Given this list of marker genes RILPL2, ARF4, COX18, ITPKB, FLRT3, CPSF7, FXYD4, RND3 (NCBI Gene Id 390), HAMP, MFSD1, GHITM, ATP6V0A2, TAGLN2, NIPAL1, FKBP15, CCL17, FNBP4, TUBA8, PRPF38B, GLIPR2, GRINA, CSF3, SLC4A1AP, ABR, TMCC3, LUM, TMOD3, TAPT1, MAPKAP1, CDS1, ITGA4, MIR383, VTI1A, ANKFN1, CCDC6, LARP4B, CYRIA, GLRA2, FPR1, HORMAD1, POU2F2, HDAC9, TMEM30A, MARCHF1, GJA1 (gap junction protein alpha 1), FGF23 (NCBI Gene Id 8074), EFNA2, FAM53C (NCBI Gene Id 51307), ITGB1, RAP2A, CD82, ADCY6, GPR108 (G protein-coupled receptor 108), ADM, NXPE3, PPARD, SERPINE2, RLIM, EEIG2, KLHL5, MSI2, ADAMTS1, TRIP13, LYSMD2, RBFOX2, SLC39A2, FLYWCH1, SPTLC2, ARHGAP8, MYBL2, KCNA1, SLC26A4, GTPBP2, EIF4G3, RDH12, KLF6, TMEM39A, HK2, IL1RAP, FOXP4, TBC1D9B, MIR30A, FAH, ITGAV, PDLIM4, SPIN1, LRRC32, PHC2, CCBE1, N4BP1, SPHK1, TBC1D10B, RNF4, OPA3, TLE3, GPR151, MFF, CHD1, BAMBI, ITM2A, LTA (lymphotoxin alpha), DHPS, VASP, SEMA4F, CDK14, MTHFD2, TIMELESS, MECP2, RBMX2, GPM6B, ACVR1B, CAPN5, DTWD1, SEMA4D, CD34, URGCP, PTTG1, GMPPB, PDZK1IP1, PDGFRB, FBXW11, CTSK, GRHL1 (grainyhead like transcription factor 1), SSX9P, TMEFF1, PPP1R3B, SLC25A10, CNDP2, GATAD2A (NCBI Gene Id 54815), GFI1, SRD5A3, ZFAND2A, HDLBP, RBL1, TMEM266, SLC25A25, TEX11, DNMT3A, ST3GAL3, GEM, SPACA6, LCK, HRC (NCBI Gene Id 3270), FAM20B, BMP1, ICAM1 (intercellular adhesion molecule 1), SGMS2, HMGXB4, CXCL3, AHI1, FYCO1, TMEM101, HPS3, EDEM2, XYLT2, FHL3, PMP22, TICAM2, CPA6, here is a description of the gene set: species: Homo sapiens Human Gene Set: GSE9509_10MIN_VS_30MIN_LPS_AND_IL10_STIM_IL10_KO_MACROPHAGE_DN from publication El Kasmi KC, Smith AM, Williams L, Neale G, Panopoulos AD, Watowich SS, Häcker H, Foxwell BM, Murray PJ (PMID 18025162) Genes down-regulated in macrophages with IL10 knockout treated by LPS and IL10: 10 min versus 30 min. IL-10 regulates anti-inflammatory signaling via the activation of STAT3, which in turn controls the induction of a gene expression program whose products execute inhibitory effects on pro-inflammatory mediator production. Here we show that IL-10 induces the expression of an ETS family transcriptional repressor, ETV3 and a helicase family co-repressor, SBNO2 (Strawberry notch homolog 2) in mouse and human macrophages. IL-10-mediated induction of ETV3 and SBNO2 expression was dependent upon both STAT3, and co-stimulus through the TLR pathway. We also observed that ETV3 expression was strongly induced by the STAT3 pathway induced by IL-10 but not STAT3 signaling activated by IL-6, which cannot activate the anti-inflammatory signaling pathway. ETV3 and SBNO2 specifically repressed NF-kB-mediated transcription and can physically interact. Collectively our data suggest that ETV3 and SBNO2 are components of the pathways that contribute to the downstream anti-inflammatory effects of IL-10. We compared expression profiles of macrophages isolated from IL-10 -/- mice. Macrophages were treated with either LPS or LPS plus IL-10. Treatment times were 10, 20 and 30 minutes.